Given this list of marker genes RTTN, DZIP1, CCP110, FOXJ1, CROCC, here is a description of the gene set: Human Gene Set: GOBP_CILIARY_BASAL_BODY_ORGANIZATION species: Homo sapiens A process that is carried out at the cellular level which results in the assembly, arrangement of constituent parts, or disassembly of a ciliary basal body, a short cylindrical array of microtubules and associated proteins found at the base of a eukaryotic cilium (also called flagellum).